The following is a description of a gene set: Glycolysis and gluconeogenesis Mouse Gene Set: WP_GLYCOLYSIS_AND_GLUCONEOGENESIS species: Mus musculus, and this is the list of marker genes: Ldha, Pdhx, Pgk2, Gapdhs, Gapdh, Gpi1, Mdh1, Ldhc, Pcx, Ldhal6b (lactate dehydrogenase A-like 6B), Hk3, Pgam2, Pgk1, Aldoa, Pdhb, Dld, Slc2a2 (NCBI Gene Id 99576), Hk1, Ldhb, Pfkl, Got1, Got2, Slc2a3, G6pc1, Slc2a5, Mpc1, Tpi1, Fbp1 (fructose bisphosphatase 1), Pklr, Mdh2, Dlat, Slc2a1, Pfkm, Pkm, Gck, Aldoc, Eno3, Slc2a4, Mpc2, Pck1, Eno2, Fbp2, Aldob, Pfkp, Eno1, Hk2, Pdha1, Pgam1, Pdha2